The following is a description of a gene set: Human Gene Set: GOBP_CALCIUM_ACTIVATED_PHOSPHATIDYLCHOLINE_SCRAMBLING The movement of a population of phosphatidylcholine molecules from one leaflet of the plasma membrane bilayer to the opposite leaflet as a result of a calcium stimulus. species: Homo sapiens, and this is the list of marker genes: ANO4, ANO9, ANO6, ANO3, PLSCR4